Given this list of marker genes MT1B, MT2A, MT1E, MT1X, MT1M, MTF1, MT1G, SNCB, MT1F, MT4, MT1H, MT3, CSRP1, MT1A, here is a description of the gene set: part of: Cellular responses to stimuli Reactome Pathway: Response to metal ions species: Homo sapiens Though metals such as zinc, copper, and iron are required as cofactors for cellular enzymes they can also catalyze damaging metal substitution or unspecific redox reactions if they are not sequestered. The transcription factor MTF1 directs the major cellular response to zinc, cadmium, and copper. MTF1 activates gene expression to up-regulate genes encoding proteins, such as metallothioneins and glutamate-cysteine ligase (GCLC), involved in sequestering metals. MTF1 represses gene expression to down-regulate genes encoding transporters that import the metals into the cell. During activation MTF1 in the cytosol binds zinc ions and is translocated into the nucleus, where it binds metal response elements in the promoters of target genes. Activation of MTF1 by cadmium and copper appears to be indirect as these metals displace zinc from metallothioneins and the displaced zinc then binds MTF1.<br>Metallothioneins bind metals and participate in detoxifying heavy metals, storing and transporting zinc, and redox biochemistry.